The following is a description of a gene set: species: Homo sapiens Any process that increases the rate, frequency, or extent of the Wnt signaling pathway through beta-catenin, the series of molecular signals initiated by binding of a Wnt protein to a frizzled family receptor on the surface of the target cell, followed by propagation of the signal via beta-catenin, and ending with a change in transcription of target genes. Human Gene Set: GOBP_POSITIVE_REGULATION_OF_CANONICAL_WNT_SIGNALING_PATHWAY, and this is the list of marker genes: MIR346, LGR6, CSNK1G1, PRDM15, TNKS, FZD9, LYPD6, SBNO1, ASPM, TGFB1, UBE2B, DLX5, RUVBL1, BIRC8, MIR145, BMAL1, HHEX, SULF2, EGFR, ADNP, GPC3, PPM1B, ATP6AP2, RSPO2, WLS, TBL1XR1, MIR501, VPS35, EDA, DAAM2, ZBED3 (NCBI Gene Id 84327), DKK2, COL1A1, CSNK1G3, PLEKHA4, RSPO1, DDX3X (NCBI Gene Id 730543), GID8, RNF220, NFKB1, XIAP (X-linked inhibitor of apoptosis), WNT10B, SMURF2, PPP2R3A, GSKIP, RSPO4, BAMBI, GPRC5B, LGR4, CCAR2, FAM53B, LRRK1, SFRP2, ADGRA2, UBR5, WNK1, SMAD3, TMEM9, FGF10, ZEB2, WNK2, DAPK3, USP8, MIR26A1, CDH3, RNF146, CSNK1D, CAPRIN2, MIR29B1, RSPO3, EGF, TMEM198, TBL1X, TRPM4, SRC, POU5F1, RBPJ (recombination signal binding protein for immunoglobulin kappa J region), SPIN4, TNKS2, YAP1, PIN1, LRRK2, CSNK1E, LGR5, PPM1A, USP34, SFRP1 (secreted frizzled related protein 1), WNT3A, USP47, KANK1, DACT1, MIR1260B, PTK7, CSNK1G2, MIR183, SOX4, NRARP, RPS12, JRK, AMER1, CTDNEP1, PPM1N (NCBI Gene Id 147699), SEMA5A, FGF2, SFRP4, FGF9, NLE1, VCP, SCEL, FGFR2 (fibroblast growth factor receptor 2), FRAT1 (FRAT regulator of WNT signaling pathway 1), TTC21B, RECK, GPC5, ILK, JUP